Given this list of marker genes ANGPT4, TEK, PTPN11 (protein tyrosine phosphatase non-receptor type 11), NRAS, PIK3R1, ANGPT1, GRB7, ANGPT2, SHC1, PIK3CA, DOK2, GRB2, KRAS, PIK3R2 (NCBI Gene Id 5296), GRB14, HRAS, SOS1, PIK3CB, here is a description of the gene set: Tie2 Signaling Human Gene Set: REACTOME_TIE2_SIGNALING studied in species Homo sapiens